Given this list of marker genes PDIA6, PDIA4, CLU, SPP1, AZGP1, LGALS3BP, TMEM59, APLP2, LRPAP1, APMAP, EPRS1, HLA-C, SIL1, EPCAM, TIMP1, MAGED2, NEAT1, MALAT1, HSPA5, GRN, CFI, OS9, GGH, TSPAN1, HLA-A, PIGT, PSAP, DDOST (dolichyl-diphosphooligosaccharide--protein glycosyltransferase non-catalytic subunit), CTSA, LAMP1, HSP90B1, GDF15, SERPINA1, ATP6AP2, PPIB, ITM2B, TM9SF2, SLC3A2, PRDX4, SERPINE2, EPHX1, CTSL, LMAN2, APP, HEXB, ATP6AP1, LAMP2, PDIA3, LAPTM4A, RPN2, here is a description of the gene set: from publication Gavish A, Tyler M, Greenwald AC, Hoefflin R, Simkin D, Tschernichovsky R, Galili Darnell N, Somech E, Barbolin C, Antman T, Kovarsky D, Barrett T, Gonzalez Castro LN, Halder D, Chanoch-Myers R, Laffy J, Mints M, Wider A, Tal R, Spitzer A, Hara T, Raitses-Gurevich M, Stossel C, Golan T, Tirosh A, Suvà ML, Puram SV, Tirosh I (PMID 37258682) Human Gene Set: GAVISH_3CA_MALIGNANT_METAPROGRAM_10_PROTEIN_MATURATION Genes upregulated in subsets of cells of a given type within various tumors species: Homo sapiens In this study, an extensive analysis was conducted to define meta-programs (MPs) capturing intra-tumor heterogeneity across a spectrum of tumor types. The approach utilized non-negative matrix factorization (NMF) to analyze each cell type separately within individual tumor samples. This involved the analysis of malignant cells, macrophages, fibroblasts, endothelial cells, epithelial cells, T-cells, and B-cells. NMF was executed with varying parameter values (K=4, 5, 6, 7, 8, 9), thereby generating 39 programs for each cell type per sample. Each NMF program was summarized by the top genes based on NMF coefficients.\nRobust MPs were then delineated for each cell type using a set of stringent criteria, including recurrence within the same tumor, similarity to programs in other tumors, and non-redundancy within a tumor. Subsequently, these robust NMF programs were clustered (per cell type) based on Jaccard similarity, leading to the identification of MPs associated with each cell type.\nTo enhance the quality of the MPs, a refinement steps were undertaken, involving the removal of MPs suspected of reflecting low-quality data (with an overrepresentation of ribosomal proteins or mitochondrial-encoded genes), single-study inclusion, or similarity to miss-annotated cell types.